The following is a description of a gene set: Increased susceptibility to enteroviral infections, as manifested by recurrent episodes of enteroviral infection. species: Homo sapiens Recurrent enteroviral infections Human Gene Set: HP_RECURRENT_ENTEROVIRAL_INFECTIONS, and this is the list of marker genes: IGHM, BTK, RAG2, SP110, RAG1